Given this list of marker genes Slc25a4, Pi16, Sorbs2 (sorbin and SH3 domain containing 2), Zfp418, Agtr2, Gsk3b, Camk2d, Gata4, Col14a1, Adrb1, Adra1b, Trip10, Pdlim5, Dyrk1a, Nr3c1, Mtor, Yy1, G6pdx, Prkg1, Igf1, Ppara, Ang2, Ddx39b, Ctdp1, Tomm70a, Hamp2, Meis1, Adra1a, Map2k4, Cav3, Myocd, Hamp (NCBI Gene Id 84506), Ep300, G6pd2, Akap13, Akap6, Rbm10, Rgs2, Foxp1, Rgs4, Parp2, Sirt1, Pak1, Pin1rt1, Fdps, Agt, Gsk3a, Pin1, Edn1, Ccn4, here is a description of the gene set: The enlargement or overgrowth of all or part of the heart muscle due to an increase in size of cardiac muscle cells without cell division. This process contributes to the developmental growth of the heart. Mouse Gene Set: GOBP_PHYSIOLOGICAL_CARDIAC_MUSCLE_HYPERTROPHY species: Mus musculus